Given this list of marker genes Spef1, Hydin, Dnajb13, Cfap91, Spag17, Rsph9, here is a description of the gene set: species: Mus musculus Mouse Gene Set: GOBP_AXONEMAL_CENTRAL_APPARATUS_ASSEMBLY The aggregation, arrangement and bonding together of a set of components to form an axonemal central apparatus.